The following is a description of a gene set: Benign congenital lesions of the periauricular soft tissue consisting of a blind-ending narrow tube or pit. studied in species Homo sapiens Human Gene Set: HP_PERIAURICULAR_SKIN_PITS Periauricular skin pits, and this is the list of marker genes: GNAI3, STAG2, MITF, KCNJ2, B3GLCT, EDN1, NPHP3, AUTS2, FBXO11, ANK1, TFAP2A, LRP1, GPC3, FGFR2, FLT4, GSC, NSD2, XYLT2, CITED2, HNRNPK, UBE2A, WBP11, MED12, FGFRL1, PLCB4, PPP1CB, KDM6A, ZFPM2 (zinc finger protein, FOG family member 2), DICER1, MID1, CPLX1, NKX2-6, EIF2AK3 (NCBI Gene Id 9451), LETM1, JAG1, GATA4, GPC4 (NCBI Gene Id 2239), CTBP1, GATA5, PAX1, GATA6, SALL1, TRPM3, H4C9, NELFA, TBX1, EDNRA, KMT2D, SIX5, RAB23, KAT6A, CRELD1, GDF1, KDR (kinase insert domain receptor), PIGG, RERE, SIX1, SYK, GJA5, HK1, ZNF462, SPECC1L, EYA1, POLR1D, NKX2-5, FLNA (NCBI Gene Id 8272)